Given this list of marker genes Gls, Scn3a, Mlst8, Tnf, Akt1, Grm3, Slc17a7, Cacna1a, Scn2b, Stx8, Rasgrf1, Mtor, Fgf13, Cacna1b, Gabra4, Epb41l3, Gria4, Slc16a1, Slc1a2 (NCBI Gene Id 98863), Slc6a1, Cacna2d3, Gabbr1, Pik3ca, Pcdh19, Gabrb1, Cacnb1, Gabra3, Mapkap1, Maob, Kcnj3, Gria3, Ldha, Gfap (glial fibrillary acidic protein), Grin1, Cacnb3 (calcium channel, voltage-dependent, beta 3 subunit), Slc38a3, Cacnb4 (calcium channel, voltage-dependent, beta 4 subunit), Gabrb3, Gad1, Ctps2, Mapk11, Slc2a3, Stxbp1, Slc16a7, Gabbr2, Rictor, Gabra1, Prr5l, Ldhb, Prr5, Grin2a, Stx16, Gria1, Slc12a5, Nfkb1, Scn1a, Glul, Stxbp3, Kcna2, Camk2a, Scn3b, Maoa, Slc1a3, Chd2, Kcnj9, Ppp1r1b, Kdr, Scn4b, Scn1b, Kcnj10, Gad2, Slc2a1, here is a description of the gene set: Mouse Gene Set: WP_DRAVET_SYNDROME_SCN1AA1783V_POINT_MUTATION_MODEL Dravet syndrome: Scn1a-A1783V point mutation model studied in species Mus musculus